Given this list of marker genes SOCS3, CHCHD4, CACNA1B, XPO4, EZH2, AGRN, JUN, TNFSF14, KSR1, BATF, CBLN1 (NCBI Gene Id 869), MDM2, PCGF5, IL1RN, GIMAP4, BMP1, HLA-A, ST8SIA4, UBXN2A, MLLT6, PIGV, NGEF, IL15RA, LHX8, RIN1, FUT8, TRAF1, RPRM, FLVCR2, BCL3, CACNA2D3, RBFOX1, NIBAN1, SDC1, RND3, DOCK10 (dedicator of cytokinesis 10), MKX, ELOC, STX11, AOC3, NUDT21, F11R, UBTFL1, DUSP10, AZIN1, ABI3BP, RPE, GRHL1, SEH1L, GJC1 (gap junction protein gamma 1), ATP2A2, GK5, PTGES, LTA, FAM178B, PPP1R15A, L2HGDH, DDX11, CD207, IL2RA, NOP2, RAD23A, GADD45B, MYEF2, SLAMF1, UNC13B, SRGN, LBX2, TMCC3, IL6, EBI3, IFT81 (NCBI Gene Id 83713), TLR7, UNC79, SYDE2, DNPH1, UBALD2, PHIP, KDR, ETF1, GUCY1B1, ATN1, BCL2L1, EPHB3, TSPAN2, NCEH1, AOPEP, FCRL1, CDC25A (cell division cycle 25A), NFKBIZ, ZMYND19 (NCBI Gene Id 116225), HYCC1, BSPRY, CHRNE, TKTL1, NOTCH1, CITED2, COX4I2, CISH, ADCY8, SLC25A33, EPS8L2, TM6SF2, FAM81B, IRGM, ERO1A (endoplasmic reticulum oxidoreductase 1 alpha), DENND3, SLC7A3 (solute carrier family 7 member 3), TMEM174 (transmembrane protein 174), PPP3R2, TMTC2, NR6A1, GABRB2, CEP83, IRF8, CRTC2, TFRC, SHMT1, SERPINB9, INSL6, C2CD4B, LAG3, DHRS13, SWAP70, SEMA7A, NFIL3, TFDP1, MIB1, LIPG, TSPAN8, KIAA0040, GABRE, HPRT1, MYBL2, PLSCR1, UTP6, OSM, RNF157, HAO1, IFNG, DENND5A, FEZF1, TLE6, HNF1B, DUSP14, NHSL1, IRF1, TM4SF5, USP31, KCNMB2, PEX11G (NCBI Gene Id 92960), LRATD2, SLC36A2, SOCS1, CDK5R1, SCHIP1, OR7C1, SNUPN, HSD11B1, CATSPER1, RHBDL3, CD81 (CD81 molecule), CD200, CYP21A1P, IFITM3, SYBU, RFX5, BPIFA1, HK2, CLIP1, CPNE3, SIAH2, EDA2R, POMT2, CACNB2, NEFL, OR6A2, ARID5A, SLC7A1, DDX18, RAB34, QPRT, LACC1, SLC23A3, SPIRE1, RBM17, FAM241A, TBX21, PTGFR, BASP1, PFDN4, JMY, PLXNC1, TLCD1, NFKBIB, IFNLR1, FAM89A, KCTD14, AEBP2, here is a description of the gene set: species: Homo sapiens from publication Hale JS, Youngblood B, Latner DR, Mohammed AU, Ye L, Akondy RS, Wu T, Iyer SS, Ahmed R (PMID 23583644) CD4 T follicular helper (Tfh) cells provide the required signals to B cells for germinal center reactions that are necessary for longlived antibody responses. However, it remains unclear whether there are CD4+ memory T cells committed to the Tfh lineage after antigen clearance. Using adoptive transfer of antigen-specific memory CD4+ subpopulations (based on CXCR5 and Ly6c expression)in the LCMV infection model, we found that there are distinct memory CD4+ T cell populations with commitment to the Tfh and Th1 lineages. Our conclusions are based on gene expression profiles, epigenetic studies and phenotypic and functional analysis. The gene expression profiles of virus-specific CD4 T cell subets at effector and memory stages is presented here. Genes down-regulated in CD4 SMARTA effector T cells during acute infection of LCMV: follicular helper (Tfh) versus Ly6c int CXCR5+. Human Gene Set: GSE43863_TFH_VS_LY6C_INT_CXCR5POS_EFFECTOR_CD4_TCELL_DN